Given this list of marker genes Gja5, Akap6, Kcnh2, Scn5a, Pde4d, Scn1a, Kcne1, Scn2b, Gata4, Bin1, Cav1, Ctnna3, Kcnn2, Cav3, Stc1, Kcnq1, Pik3ca (phosphatidylinositol-4,5-bisphosphate 3-kinase catalytic subunit alpha), Cacna1c, Ryr2, Akap9, Trpm4, Uty, Kcne4, Adcy10 (NCBI Gene Id 73777), Abcc9, Ank2, Cacna1d, Cacna2d1, Kcnj5 (potassium inwardly-rectifying channel, subfamily J, member 5), Flna, Scn3b, Kcna5, Pkp2, Sri, Scn1b, 3425401B19Rik, Slc9a1, Casq2, Kcne5, Kcnj8, Kcnj2, Pln, Strit1, Hcn4, Atp1a1 (NCBI Gene Id 229653), Atp1a2, Kcnd3, Camk2d, Adrb1, Cacnb2, Rnf207, Nedd4l, Adora1, Dsp, Scn4b, Atp2a2, Kcne3, Sgcd, Dsg2, Cacna1h, Gsn, Dsc2, Fxyd1, Sumo1, Kcne2, Dlg1 (NCBI Gene Id 320792), Snta1, Fgf13, Myh7b, Nup155, Rangrf, Atp2a1, Jup, Gpd1l, here is a description of the gene set: studied in species Mus musculus The actin filament-based process in which cytoplasmic actin filaments slide past one another resulting in contraction of a cardiac muscle cell. Mouse Gene Set: GOBP_CARDIAC_MUSCLE_CELL_CONTRACTION